The following is a description of a gene set: Human Gene Set: GOMF_GTPASE_ACTIVATING_PROTEIN_BINDING Binding to a GTPase activating protein. studied in species Homo sapiens, and this is the list of marker genes: FMNL1, FMNL3, PLCD1, NKIRAS1, PLXNB1, CDH1, PIN1, NKIRAS2, TUBB, RGS14, GAPVD1